Given this list of marker genes AP1M1, SNAPC5, PLEKHM1, HACL1, CIITA, PLP2, IL18R1, UFSP1, MAP2K6, SCMH1, DCXR, VSIG8, XYLT1, DAP, GNB1L, RPS6KA2, ANAPC13, PLBD1, PACS1, ALDOC, MAZ, CSF1R, GTF3C4, NRM, ATP2A3 (NCBI Gene Id 489), PSMA8, ST6GAL1, ABCA3, TPRG1L, IYD, DPYSL2, SYNE1, KASH5, NIBAN3 (NCBI Gene Id 199786), SULF2, NAA20, TBX6, HDAC9, GCDH, PDE2A, METRN (NCBI Gene Id 79006), GM2A, HAVCR1, SELENOP, MVB12B, CCR6, PPM1E, NDUFV3, KNDC1, ZER1, GSN, SFXN3, FAM117B, RASGRP4, TMEM200C (transmembrane protein 200C), PLCB2, TXNDC15, ADD1, PDE4A, SV2B (NCBI Gene Id 9899), CTSG, EMP3, DYRK1A, KIF1C, DGKQ, IQSEC1, VAMP1, FN1, NFAM1, ENDOU, EXT2, MAP3K6, CPEB2, KCNAB1, ALDH2, YPEL3, GPD1L, RDH13, CBY1, DLG2, COQ8A, ACSS1, ST3GAL1, RFK, GPR146, FOXJ2, LBH, GATC, B3GNT8, RAPGEF4, GALNT10, KLF11, HES1, SNIP1, LIPH, CPM (NCBI Gene Id 1368), KCNJ16, CACNA1E, HEATR6, TSC2, DYRK1B, YPEL5, TRPM2, BMF (NCBI Gene Id 90427), ALDH4A1, DAB2, IQUB, ARL2BP, BRF1, PIGL, FOXO1, ADAMTS10, FCGRT, FLNA, IDS, BCHE, ULK2, C2CD2L, TMEM175, ITGAX, PSTK, ITGAD, CDKL1, NAAA, ACOT12, CBX8, PPP6R2, UCMA, GSPT2, ADD3, KLF3, SH3GLB2, FAM234A, SLC2A3, SNX29, GPAT3, TPCN1, SERTAD4, TPRN, GLCCI1, CRAMP1, EIF2AK3, ZYX, SHISA9, IL5, CNN2, ADGRE5, here is a description of the gene set: species: Homo sapiens from publication Dudziak D, Kamphorst AO, Heidkamp GF, Buchholz VR, Trumpfheller C, Yamazaki S, Cheong C, Liu K, Lee HW, Park CG, Steinman RM, Nussenzweig MC (PMID 17204652) Human Gene Set: GSE6259_FLT3L_INDUCED_DEC205_POS_DC_VS_CD8_TCELL_UP Genes up-regulated in cells from Flt3L Melanom injected mice: splenic DEC205+ dendritic cells versus CD8 T cells. Dendritic cells (DCs) process and present self and foreign antigens to induce tolerance or immunity. In vitro models suggest that induction of immunity is controlled by regulating the presentation of antigen, but little is known about how DCs control antigen presentation in vivo. To examine antigen processing and presentation in vivo we specifically targeted antigens to the two major subsets of DCs using chimeric monoclonal antibodies. Unlike CD8+ DCs that express the cell surface protein CD205, CD8- DCs, which are positive for the 33D1 antigen, are specialized for presentation on MHC class II. This difference in antigen processing is intrinsic to the DC subsets and associated with increased expression of proteins associated with MHC processing.